The following is a description of a gene set: studied in species Mus musculus Any process that decreases the rate, frequency, or extent of the series of molecular signals generated as a consequence of a transmembrane receptor serine/threonine kinase binding to its physiological ligand. Mouse Gene Set: GOBP_NEGATIVE_REGULATION_OF_TRANSMEMBRANE_RECEPTOR_PROTEIN_SERINE_THREONINE_KINASE_SIGNALING_PATHWAY, and this is the list of marker genes: Vwc2l, Sfrp2, Tgfbr3, Peg10, Ppara, Eid2, Chrdl2, Bmper, Ski, Brms1 (NCBI Gene Id 107392), Fstl3, Ing2, Pin1, Vasn, Smad6, Fst, Nbl1, Ing1, Tbx20, Trim33, Chrdl1, Adamtsl2, Ctdspl2, Synj2bp, Sap30, Fbn2, Skil, Grem2, Smurf1, Abl1, Gpr155, Onecut1, Lemd2, Dkk1, Snx25, Nog, Sorl1, Dnm2, Bcl9l, Lemd3, Lrp2, Sirt1 (NCBI Gene Id 93759), Cd109, Htra3, Ryr1, Il17rd, Pbld1 (NCBI Gene Id 68371), Spry2, Fkbp1a, Ogt, Zfp451, Wnt5a, Xbp1, Wnt1 (NCBI Gene Id 22408), Brms1l, Grem1, Rbbp7, Fbn1 (NCBI Gene Id 99016), Nrros, Cav2, Rbpms2, Sost, Aspn, Fam89b, Snx1, Slc2a10, Smurf2, Mir675, Erfe, Igsf1, Ldlrad4, Stub1, Cer1, Tob1, Chrd, Chst11, Rbbp4, Tet1, Ints9, Pmepa1, Pbld2, Sap130, Tgfb3, Lefty1, Notch1, Spart, Tnfaip6, Adam17, Prdm16, Cidea, Trp53, Arid4a, Suds3, Pdpk1, Dact2, Lrp1, Cav1, Hipk2 (homeodomain interacting protein kinase 2), Htra1, Usp15, Ltbp1, Hspa5, Cdh3, Snx6, Crim1, Sfrp1, Spred3, Wfikkn2, Dlx1, Nanog, Gdf15, Ppm1a, Sinhcaf, Spred1, Magi2, Twsg1, Tmprss6, Hjv, Gdf3, Bambi, Pparg, Ovol2, Spry1, Skor2, Mir210, Onecut2, Sin3a, Pin1rt1, Vwc2, Cilp, Emilin1, Dand5, Sap30l, Fzd1, Strap, Lrrc32, Tmem53, Ccn3, Rasl11b, Tcf7l2, Mtmr4, Nepn, Glg1, Veph1, Wfikkn1, Zbtb7a, Hdac2, Bmp2, Hdac1, Arid4b, Ucma, Skor1, Cripto, Sostdc1, Acvr1, Smad7, Spred2, Nkx2-1